The following is a description of a gene set: Human Gene Set: AP1_Q2_01 Genes having at least one occurrence of the motif TGACTCANNSKN in the regions spanning 4 kb centered on their transcription starting sites. This matches the JUN transcription factor binding site V$AP1_Q2_01 (v7.4 TRANSFAC). species: Homo sapiens, and this is the list of marker genes: FLI1, S1PR2, OMG, ADAMTSL1, TINAGL1, RB1CC1, NCDN, NRAS, RNF144B, COBL, KRT16, EPHB2, KCNH2, SLC41A1, TMCC1, PTPRH (NCBI Gene Id 5794), SNX10, SLC9A1, BARHL2, NKAPD1, KLF5, MORF4L2, RIMS1, ADCY8, SYTL1, ARPC5L, CKMT1B, CLDN4, C2CD2L, TAC1, HSPB8, GPR158, CLRN1, VIT, PLEKHH3, LIMK2, NR1D1, MMP1, KRT8 (NCBI Gene Id 90177), NUAK1, GJB3, HS3ST3B1, EIF4G1, CLIC1, CILK1, SEMA3B, LAMC2, SLC6A5, GGN, DIRAS1, PSME4, EIF4E, HCN3, TUBB4A, PDZD9, DSG1, ENO2, ATP1B1, MRGPRF, COL27A1, YPEL5, LPP, RAP2C, PCSK1N, CYTOR, EPB41L1, MECP2, UBALD1, GASAL1, AQP5, GAB2, TFE3, GPR3, PIH1D2, CMAS, METAP1, CPA6, HBEGF, NR0B2, PROSER3, TRAPPC3, GPR162, PSMD11 (NCBI Gene Id 5717), FLNC, LUC7L, P2RX6, RNF149, IMPDH1, STN1 (NCBI Gene Id 79991), TRAK2, HPSE2, HOMER2, RTN4, RAP1GAP2, SKIDA1, ELK3, SLITRK6, NCOA6, RIPK4, PLA2G2E, COL1A2, HCLS1, KAZN, SCOC, SRGAP2, TCF12, ELAVL2, GFAP, RGS8, LTBP3, NFATC4, MGST3, IL9, SRC, KLF12, GPR87, KLHL41, CMTM2, CA9, SYP, LONRF3, EYA1, BRD2, PAK6, SHANK2, HMCN1, SFXN5, COQ8B, AXIN2, SMARCA2, ADAMTSL2, PERP, CHRM1, DLG4, DNAH5, UCN2, RAB34, USP3, MYBPH, ACADVL, IRAK1, TENT5B, SLC6A14, FOXA1, ADORA2A, FOXL2, XIRP1, PLCD1, CNTF, CLSTN3, PCDH9, WDFY3-AS2, ADAM15, RIN1, XPO6, AIF1L, BRINP1, OR2F1, UBE3A, PI15, ANK3, NDEL1, CDKN1A, LINC02908, ELAVL4, FOSL1, OLR1, STRADB, AKAP1, PKP3, FHOD1, PTPRN, H3-3B, TNXB, LMOD3, TRIB1, NTN4, STK40, AKT3, RAB30, PPP2R2C, SNCB, FAM180A, FAP, DUSP14, TMEM104, LRCH4, HSPB6, NDRG2, EFNA1, RBPJ, SLC30A3, ZNF385B, SLC4A11, CLDN15, SERTAD1, KLHL40, MITF, PTP4A1, IL1RN, NEBL, USP13, CXCL14, DYRK1A, EEF1A1, BICDL1, PPP1R9B, PADI3, KRTCAP2, PADI4, PRPF38B, RUNDC3A, RIT1, GPR55, RTN3, TMEM54, KDM3A, DDR2, TCF4, LAMA3, LMNA, CRYGS, POLR1G, BAG2, IL11, XPOT, WDFY3, CLC, ORAI1, NRN1L, KLF15, UBE2R2, RBPMS, MIDEAS, DUSP9, DYNC1H1, FAM53B, C1orf210, ZFAND5, GSE1, LDB3, MPV17, MMP12 (matrix metallopeptidase 12), SLC9A8, MAST2, SQSTM1 (sequestosome 1), DNAJA4, AGPAT4, TNFRSF12A, SLC26A9, WNT6, TRIM46, ITPKC, PPP2CA, DGKA, PSMD4, WASF2, FBXO24, NLGN3, RPL23A, CSTPP1, ABCA2, LAMB3 (NCBI Gene Id 3914), SH3RF2, VASP, RHBDF1, RPS20, TTC1, MYOZ2, NAT9, TRIML1, DYSF, KCNK10, STARD13, REXO2, EN1